The following is a description of a gene set: Human Gene Set: FAN_EMBRYONIC_CTX_BIG_GROUPS_GLIAL studied in species Homo sapiens from publication Fan X, Dong J, Zhong S, Wei Y, Wu Q, Yan L, Yong J, Sun L, Wang X, Zhao Y, Wang W, Yan J, Wang X, Qiao J, Tang F (PMID 29867213), and this is the list of marker genes: TIMP1, ADD3, LYPD1, RTN3, ATP1B2, SEMA6A, S100A16, HOPX, DTNA, CLU, PRCP, SEC11C, DAG1, CCDC80, ANXA5, TSPAN6, MDK, GPM6B, TPI1, CKB, HACD3, OLIG1, RFX4, RHOC, EPN2, GRHPR, PHGDH, BMP7, IFI27L2, MT2A, CST3, LRRTM3, PRNP, OAT, MLC1, DNER, GCSH, CXCL14, TM7SF2, CNN3, LRPAP1, TSC22D4, HAPLN1, FABP5, PSAT1 (NCBI Gene Id 29968), AASS, PTN, BTBD17, ENO1, PON2, PLPP3, ITGB8, TMEM9B, VIM, CYP51A1, TSPAN3, RAB31, EDNRB, MIR9-1HG, SIGMAR1, F3, DCXR, HEY1, NTM, IDH1, TNC, SCRG1, FIBIN, MFGE8, MYO10, SLC1A2, SLC1A3, MYO6, PRXL2A, WSCD1, SERPINE2, BCHE, MSMO1, TRIB2, LUZP2, AIF1L, MT3, ARL6IP1, TTYH1, SHISA4, RAMP1, ALDOC, ITM2C, GRID2, RCN1, PTTG1IP, ARHGEF26, CPE, PMP2, FABP7, CD63, CD9, CBR1, DAD1 (defender against cell death 1), RDH11, LITAF, SNX3, SLITRK2, LAPTM4B (NCBI Gene Id 55353), S100B, LIMA1, NKAIN4, NDRG2, IDI1, GATM, CADM2, TMBIM6, BTG3, TXNDC12, BCAN, TAOK3 (NCBI Gene Id 51347), FHL1 (four and a half LIM domains 1), SPON1, SCD, DHCR7, ADGRG1, ATP1A2, NOVA1, PTPRZ1, SRI, ETV1, TSPAN7, SOX2, PDE4B, LDHB, DDAH1, NTRK2, DBI